The following is a description of a gene set: studied in species Mus musculus Mouse Gene Set: REACTOME_REGULATION_OF_PTEN_GENE_TRANSCRIPTION Regulation of PTEN gene transcription, and this is the list of marker genes: Rptor, Hdac1, Lamtor1, Lamtor4, Lamtor2, Mlst8, Mta1, Lamtor5, Chd3, Maf1, Rragb, Mta2, Rragc, Rheb, Slc38a9, Mbd3, Rbbp4, Rraga, Rragd, Lamtor3, Sall4, Gatad2a, Chd4, Mta3, Gatad2b, Mtor, Rbbp7